Given this list of marker genes Asap1, Rasa2, Gdi2, Dock4, Arhgef12, Arap2, Depdc5, Arhgef19, Iqgap3, Arhgap5, Nprl3, Thy1, Acap3, Elmod3, Wnt11, Ralgapa2, Rgs18, Arhgap44, Rgs17 (regulator of G-protein signaling 17), Rgs9 (regulator of G-protein signaling 9), Depdc1a, Ect2 (NCBI Gene Id 99670), Rasal1, Myo9a, Arfgap3, Tbc1d22b, Ankrd27, Ophn1, Arl2bp, Arhgap18, Arhgap28, Rgs12, Mtss2, Evi5l, Acap2, Arhgdib, Llgl1, Arhgap27, Ocrl, Rabep2, Tbc1d14, Syngap1, Nf1, Dock5, Tbc1d20, Arhgap39, Sec23a, Tbc1d21, Arhgap25, Rgs6, Rabgap1l, Tbc1d2, Agap2, Gnaq, Ralgapb, Arhgef15, Lrrk2, Gdi1, Lars1, Arhgap35, Arrb1, Tbc1d10b, Arhgap6, Tbc1d15, Chm, Rgs11, Stxbp5, Arhgap17, Rgs20, Rabep1, Arhgap12, Tbc1d9b, Srgap1, Chn2, Als2, 1700006A11Rik, Tbc1d25, Nckap1l, Tbc1d30, Syde2, Rgs4, Flcn (NCBI Gene Id 216805), Ranbp1, Arhgap45, Dock2, Rap1gap2, Elmod2, Abr, Stard8, Sgsm2, Rasa1, C9orf72, Deptor, Rgs2, Arhgap33, Gnb5, Htr2b, Tbc1d4, Tbc1d2b, Stard13, Agap3, Rin1, Dab2ip, Syde1, Chml, Arhgap1, Arhgap10, Ralgapa1, Acap1, Plekhg6, Srgap2, Sgsm3, Chn1, Arhgap29, Tbc1d8b (NCBI Gene Id 75757), Usp6nl, Bcr, Rapgef2, Smap1, Rgs1, Rasa3, Rgs5, Rgs3, Sipa1, Rin3, Arhgef10l, Myo9b (NCBI Gene Id 17925), Arhgap23 (Rho GTPase activating protein 23), Rinl, Tbc1d1, Cavin4, Plcb1, Tbc1d17, Dlc1, Iqgap2, Depdc1b, Arfgap1, Rab3gap2, Racgap1, Tbc1d13, Sipa1l1, Tbc1d22a, Rab3gap1, Gmip, Prr5, Rap1gap, Arhgap4, Rasa4, Rgs10, Prex2, Rangap1, Arhgap24, Tbcd (NCBI Gene Id 77213), Rin2, Arhgap42, Elmod1 (ELMO/CED-12 domain containing 1), Arhgap22 (NCBI Gene Id 239027), Arhgap30 (NCBI Gene Id 277291), Smcr8, Rp2, Evi5, Arhgap11a, Agfg2, Tbc1d8, Srgap3, Smap2, Arhgap26, Sipa1l3, Sh3bp1, Gm1527, Asap2, Rgs7, Fam13b, Iqgap1, Prex1, Adap1 (ArfGAP with dual PH domains 1), Arhgap19, Sec23b, Tbck, Git2, Eif5, Llgl2, Arhgap36, Arhgap20, Tbc1d24, Rgs8, Arap3, Ranbp2, Tbc1d16, Arhgap21, Tbc1d10c, Rgs16, Grtp1, Sipa1l2, Agfg1, Pgam5, Jun, Tagap, Tiam2, Rabgap1, Rgs14, Arap1, Cdc42ep2, Arhgap32, Git1, Gapvd1, Tbc1d7, Als2cl, Garnl3, Arhgdia, Gipc1, Nprl2, Tbc1d10a, Dock3, Tbc1d12, Arfgap2, Rasgrp3, Tbc1d9, Rasal3, Arhgef1, Arhgap40, Tbc1d5, Stxbp5l, Tsc2, Nrp1, Adap2, Arhgap9, Asap3, Adgrb3, Arhgap31, Arhgap15, Ric8a (RIC8 guanine nucleotide exchange factor A), Sgsm1, Arhgdig, Agap1, Ralbp1, Arhgap8, here is a description of the gene set: studied in species Mus musculus Binds to and increases the activity of a GTPase, an enzyme that catalyzes the hydrolysis of GTP. Mouse Gene Set: GOMF_GTPASE_ACTIVATOR_ACTIVITY